The following is a description of a gene set: species: Homo sapiens A protein complex in which at least one of the proteins is a cytochrome, i.e. a heme-containing protein involved in catalysis of redox reactions. Human Gene Set: GOCC_CYTOCHROME_COMPLEX, and this is the list of marker genes: UQCRC2, COX8C, UQCR11, COX6B1, COX7A1, NDUFA4L2, C15orf48, MTCO2P12, MT-CO3, COX15, COX6A2, UQCRH, COX7A2L, COX7C, NDUFA4, UQCRQ, COX7A2P2, COX5B, COX7A2, UQCRHL, UQCR10, COX7B2, COX5A, UQCRFS1, UQCRFS1P1, COX6A1, COX6C, MT-CO2, BCS1L, COX7B, CYC1, COX10 (cytochrome c oxidase assembly factor heme A:farnesyltransferase COX10), UQCRB, COX8A, COX4I2, MT-CYB, UQCRC1, COX4I1, MT-CO1, COX6B2